Given this list of marker genes TPBG, OLFM1, ABAT, ITPK1, DYNLT3, TIPARP, PLA2G2F, SGK3, IGFBP4 (NCBI Gene Id 3487), RET, MED13L, FHL2, TIAM1 (TIAM Rac1 associated GEF 1), SUSD4, CALCR, SIAH2, GREB1 (NCBI Gene Id 9687), ADCY9 (adenylate cyclase 9), here is a description of the gene set: Expression of estrogen-related receptor alpha (ERRalpha) has recently been shown to carry negative prognostic significance in breast and ovarian cancers. The specific role of this orphan nuclear receptor in tumor growth and progression, however, is yet to be fully understood. The significant homology between estrogen receptor alpha (ERalpha) and ERRalpha initially suggested that these receptors may have similar transcriptional targets. Using the well-characterized ERalpha-positive MCF-7 breast cancer cell line, we sought to gain a genome-wide picture of ERalpha-ERRalpha cross-talk using an unbiased microarray approach. In addition to generating a host of novel ERRalpha target genes, this study yielded the surprising result that most ERRalpha-regulated genes are unrelated to estrogen signaling. The relatively small number of genes regulated by both ERalpha and ERRalpha led us to expand our study to the more aggressive and less clinically treatable ERalpha-negative class of breast cancers. In this setting, we found that ERRalpha expression is required for the basal level of expression of many known and novel ERRalpha target genes. Introduction of a small interfering RNA directed to ERRalpha into the highly aggressive breast carcinoma MDA-MB-231 cell line dramatically reduced the migratory potential of these cells. Although stable knockdown of ERRalpha expression in MDA-MB-231 cells had no effect on in vitro cell proliferation, a significant reduction of tumor growth rate was observed when these cells were implanted as xenografts. Our results confirm a role for ERRalpha in breast cancer growth and highlight it as a potential therapeutic target for estrogen receptor-negative breast cancer. from publication Stein RA, Chang CY, Kazmin DA, Way J, Schroeder T, Wergin M, Dewhirst MW, McDonnell DP (PMID 18974123) Genes up-regulated by estradiol and not modulated by ESRRA in MCF-7 cells (breast cancer). species: Homo sapiens Human Gene Set: STEIN_ESTROGEN_RESPONSE_NOT_VIA_ESRRA